The following is a description of a gene set: part of: Interferon Signaling Reactome Pathway: Interferon gamma signaling Interferon-gamma (IFN-gamma) belongs to the type II interferon family and is secreted by activated immune cells-primarily T and NK cells, but also B-cells and APC. INFG exerts its effect on cells by interacting with the specific IFN-gamma receptor (IFNGR). IFNGR consists of two chains, namely IFNGR1 (also known as the IFNGR alpha chain) and IFNGR2 (also known as the IFNGR beta chain). IFNGR1 is the ligand binding receptor and is required but not sufficient for signal transduction, whereas IFNGR2 do not bind IFNG independently but mainly plays a role in IFNG signaling and is generally the limiting factor in IFNG responsiveness. Both IFNGR chains lack intrinsic kinase/phosphatase activity and thus rely on other signaling proteins like Janus-activated kinase 1 (JAK1), JAK2 and Signal transducer and activator of transcription 1 (STAT-1) for signal transduction. IFNGR complex in its resting state is a preformed tetramer and upon IFNG association undergoes a conformational change. This conformational change induces the phosphorylation and activation of JAK1, JAK2, and STAT1 which in turn induces genes containing the gamma-interferon activation sequence (GAS) in the promoter. species: Homo sapiens, and this is the list of marker genes: PML, RAF1, HLA-G (major histocompatibility complex, class I, G), TRIM17, PTPN1, TRIM8, JAK1, GBP6, GBP3, VCAM1, TRIM34, IFI30, IFNGR2, IFNGR1, GBP2, IRF4, CD44, TRIM46, GBP7, FCGR1BP, TRIM29, MAPK3, HLA-B, OAS2, PTPN6, PTPN11, TRIM10, GBP1, HLA-DQB2, OASL, HLA-DQA1, MT2A, OAS1, HLA-DPA1, CIITA, TRIM22, TRIM31, CAMK2A, PRKCD, TRIM5, HLA-E, TRIM6, TRIM48, TRIM2, HLA-C, CAMK2G, IRF6, IRF9, HLA-A, IRF2, PIAS1, SMAD7, STAT1, SUMO1, HLA-DQB1, HLA-DRB4, TRIM35, MAPK1, HLA-H, YBX1, TRIM21, TRIM25, ICAM1, B2M, PTPN2, TRIM14, TRIM38, HLA-DRA, IRF5, IRF3, CAMK2B, HLA-DPB1, TRIM3, OAS3, FCGR1A, FCGR1B, GBP5, HLA-DQA2, TRIM26, HLA-DRB3, HLA-DRB5, IRF8, HLA-F, GBP4, TRIM62, SOCS1, MID1, PTAFR, IRF1, JAK2, SP100, TRIM68, IFNG, HLA-DRB1, TRIM45, CAMK2D, NCAM1, IRF7, SOCS3